Given this list of marker genes FAS, FASLG, PTEN, PRKAR1A, PDE11A, PRLR, AKT1 (AKT serine/threonine kinase 1), CASP10 (NCBI Gene Id 843), APC, here is a description of the gene set: species: Homo sapiens Fibroadenoma of the breast Human Gene Set: HP_FIBROADENOMA_OF_THE_BREAST A benign biphasic tumor of the breast with epithelial and stromal components.